Given this list of marker genes CLEC4A, LILRA6, TNFRSF1B, TMEM127, AIF1 (NCBI Gene Id 9471), DUSP1, ARPC1B, NCF2, TYROBP, FMNL1, MYD88, ITGB2, GMFG, HK3, NAIP, ZDHHC7, TLR8, CD302, FBXL5, MYO1F, DAZAP2, HCLS1, CFP, SELL, ADA2, MAP3K3, THEMIS2, USP3, MNDA (myeloid cell nuclear differentiation antigen), RIN3, FGL2, ACAP2, CPVL, FCER1G, CD1D, LILRB3, AOAH, FES (FES proto-oncogene, tyrosine kinase), MFSD1, HCK, PPT1 (NCBI Gene Id 5538), PECAM1 (NCBI Gene Id 5175), CHST15, CYBB, TCIRG1, IQGAP1, KRR1, APOBEC3A, CD33, COTL1, GABARAP, LILRA2, CD86, BST1, MX2, CSGALNACT2, CD44, ITGAM, MS4A6A, TNFAIP2, PSAP, LILRB2, TYMP, SKAP2, FCN1, IGSF6, MAFB, IER2, GMIP, CCR1, PLCB2, RGS2, EVI2B, PLBD1, ARRB2, TLR2, MCL1, FGR, DPEP2, TBXAS1, CASP1, CTSS, S100A4, LST1, SAMHD1, STX11, CMTM6, OTULINL, LILRB1, PLSCR1, CPPED1, PYCARD, IFNGR1, PRKCD, LILRA1, IL10RA, PILRA, EVI2A, FKBP15, VNN1, PSTPIP1, CNPY3, TKT, JUNB, RAB5IF, HSD17B11, SH3BGRL3 (SH3 domain binding glutamate rich protein like 3), RHOG, NAAA, AP1S2, NOD2, here is a description of the gene set: studied in species Homo sapiens Neighborhood of CASP1 caspase 1, apoptosis-related cysteine peptidase (interleukin 1, beta, convertase) in the GNF2 expression compendium Human Gene Set: GNF2_CASP1 Neighborhood of CASP1